Given this list of marker genes FOS, JUN, PIAS2, IRF1, IL18, PPP3CA, CD86, IL2, CREBBP, CD3G, IL13, MAPK9, STAT4, MAPK8, STAT3, IL2RA, TBX21, IFNG, PRF1, HLA-DRA, CD4, PPP3R1, CD80, CD28, CD247, ETV5, IL18R1, CD3E (NCBI Gene Id 916), IL18RAP, CD3D, PPP3CB, TGFB1, here is a description of the gene set: species: Homo sapiens Human Gene Set: PID_IL12_STAT4_PATHWAY IL12 signaling mediated by STAT4 from publication Schaefer CF, Anthony K, Krupa S, Buchoff J, Day M, Hannay T, Buetow KH (PMID 18832364)